The following is a description of a gene set: from publication Chen Y, Wang X (PMID 31504780) Genes predicted to be targets of miRBase v22 microRNA mmu_miR_467g in miRDB v6.0 with MirTarget v4 prediction scores > 80 (high confidence targets). Mouse Gene Set: MIR_467G species: Mus musculus, and this is the list of marker genes: Zc3h12c, Trim59, Abi1, Srsf2, Sclt1, Zmat1, Fbxl17, Cacna1g, Zfp874b (NCBI Gene Id 408067), Aurka, Taok1, Smad1, Adamts20, Ppat, Ikbkg, Ptprb, Rc3h2, Zfp592, Rab39 (RAB39, member RAS oncogene family), Tceanc, Qrich1, Fsd1l, Erich1, Tjp2, Ttc7, Ms4a4c, Frmd6, Marchf6, Mat2b, Kbtbd3, Btf3l4, Zfp354c, Ptp4a3, Klhdc2, Tm9sf3, Cdk6, Epc2, Ccdc166, Extl2, Pias1, Tnfrsf11b, Arhgef10l, Fam8a1, Rb1cc1, Tent5a (NCBI Gene Id 320335), Ric1, Trhr (thyrotropin releasing hormone receptor), Hook3, Rnf111, Rcn2, Adra1b, Cep126, Pou2f1, Irf1, Secisbp2l, Ash1l, Cxcl5, Ankrd13c, Plxna2, Lin52, B3galt1, Prkcd, Mpzl1, Itch, Ednra, Morc3, Tbc1d24, Shoc2, Cttnbp2, Vmn1r51, Spock3, Lin54, Lss, Slc4a7, Fhip1b, Anln, Mis18a (NCBI Gene Id 77054), Fgfr2, Tlr3 (toll-like receptor 3), Phactr2, Tada1, Abcg3, Kif23, Txndc9, Hoxb3, Dusp10, Lrp12, Lrrn1 (NCBI Gene Id 72710), Trhde, Epha4, Grk6, Smad7, Clcn2, Ets1, Dach2, Arhgap6, Gata3, Herc6, Rusc2, Nup93, Zfand2a, Gnaq, Lhx8, Nfyb, Eml6, Sft2d3, Zbtb49, Pik3c2a, Gramd1c, Lats1, Akr1c20, Slc5a3, Mdp1, Akap13, Slc16a10, Pms1, Cxcl16, Rsbn1, Ptpn4, Ell2, Txlnb, Riok3, Lifr, Tshz3, Zmym2, Tfg, Far1, B3galt2, AI182371, Usf3, Fut9, Psd3, Ube2a, Klf15, Slc38a2, Pgm2l1, Sbf2, Bmp5, Nr2c2 (NCBI Gene Id 22026), Cadm2, Tnfaip8, Cmtr2, Kcne4, Arl6ip6, Smu1, Mllt3, Etaa1, Rbm39, Nek1, Lcorl, Akain1, Pdcd10, Hopx, Gucy1a2, Tmtc4, Ccdc68, Grem2, Zmym5, Scamp2, Chuk, Trdmt1, Cdc14a, Fgf4, Traf3ip1, Pip4k2c, Sema4b, Cobll1, Mast4, Scn2a, Gabpa, Cflar, Oas3, Cxxc4, Kdm6a, Osbpl8, Arap2, Plag1, Adgre4, Nhlh1, Rab11fip3, Rif1, Epha5, Zfp27, Fchsd2, Rps6ka3, Phactr4, Tob2, Piezo2, Vamp1, Pdik1l, Skint7, Cdh2, Tmem151a, Sp4, N6amt1, Mtmr12, Pfkfb2, Wdr47 (WD repeat domain 47), A830018L16Rik, Pkd2, Mpc1, Hectd2, Mzt1, Zfp148, Vps35, Zbtb10, Znrf3, Alg6, St8sia4, Fzd8, Chrdl1, Cask, Dkk3, Dmxl1 (Dmx-like 1), Crebrf, Zfand5, Arhgap35, Tnrc6c, Psma3, Kcnh8, Nxpe3, Kif16b, Trpc1, Fgf12, Zswim6, Arfgef2, Hhip, Stard13, Rad21 (NCBI Gene Id 19357), Tgfbr3, Diaph2, Zbtb2, Epb41l2, Dlx4, Usp1, Gopc, Syncrip, Dnttip2, Strbp, Cysltr1, Vps26a, Hnrnpll, Ttll7, Cep135, Kcnma1, Phf6, Lemd3, Prr12, Six6, Ddx10, Fgl2, Cul3, Prpf4b, Aff4, Zfp644, Zdhhc21, Tet3, Lypd1, Iqschfp, Necab1, Tigd5, Rab14, Kcns2, Slc30a1, Des, Polr3d, Rai1, Nck2, Nup35, Qtrt2, Rbbp5, Yes1, Rgmb, Casz1, Topbp1, Crybg3, Ubqln2, Tbc1d22b, Rev1, Grip1, Dcdc2a, Sema3a, Ewsr1 (Ewing sarcoma breakpoint region 1), Il1rap, Atosa, Med14, Cyth3, Skint9, Fignl1, Gtpbp2, Dck, Irs1, Dip2b, Hivep1, Rnf44, Fam228b, Tcf12, Rreb1, Slitrk4, Vcan, Fam118b, Sav1, Ap1g1, Csn2, Mstn, Rhobtb1, Hoxd1, Ptprr, Rasef, Sgms1, Cdc42se2 (CDC42 small effector 2), Wrnip1, Yaf2, Irf2bpl, Gabra1, Calca, Megf11, A630023A22Rik, Styx, Zfp781b, Tab2, Zc2hc1a, Tubgcp5, Prkacb, Rmnd5a, Slc1a1, Pter, Slco2b1, Neurod1, Camsap2, Lrig3, Hnrnpa3, Dennd4a, Cxcl1, Otud6b, Pik3r1, Mapk1, 1700028K03Rik, Nodal, Ctdsp1, Arl8a, Orc1, Lrp8, Ppp1r9b, Nectin4, Baz2b, Dync1li2, Evx2, Krt73, Il1b, Slc8a1 (solute carrier family 8 (sodium/calcium exchanger), member 1), Ano4, Sim1, Emc7, Eif4ebp1, Cfap20, Chrna1, Acsl4, Btaf1, Dph6, Schip1, Arl15, Wrap73, Hs3st3b1, Pak2, Wdr43, Glis3, Taf4b, Itgb1, Fbxo33, Pum2, Homer1, Kcna2, Chek2, Gtf2b, Nceh1, Cadm1, Neurod6, Mthfd1, Adamts1, Ccnc, Ccdc169, Scoc, Bche, Tpm1, Appl1, Tbx22, Adgrf5, Zfp608, Heatr5b, Igfbp1, Pira12, Snx27, Ppm1h, Serpinb9d, Cacnb2, Dleu7, Saxo2, Arhgef7, Lamtor3, Grhl3, Fam76b, Spred1, Epb41l1, Naa20, Mbnl1, Itpr1, Pafah1b1, Car8, Dapk1, Zfp521, Mkrn3, Mcu, Dnajb12, Zfp446, Utp18, Glrb, Phrf1, Filip1l, Zfp689, Cd53, Nectin3, Unk, Nfatc1, Sorcs3, Wiz, Wdfy3, Iars2, Cnbp, Ddx60, Ctsc, Rtp1, Mospd2, Itga2, Apobec3, Akap12, Rbm41, Slc7a2, Pbrm1, Akap7, Tmprss5 (NCBI Gene Id 83680), Sumf2, Slc5a8, Il3, Tulp4, Ncam2, Grm5, Dbx1, Rnf144a, Nfkbia, 1110059G10Rik, Lix1l, Grsf1, Anks1b, Fgd4, Matn2, Mbd2, Dcun1d4, Kif13a, Bmpr2, Mei4, Eri1, Vegfa, Pcf11, Apool, Pfkfb3, Myt1l, Cspp1, Mrc1, Ulk2, Atad1, Ints6l, Ctdspl2, Sf3a1, Slc6a6, Nrf1, Gm11992, Mef2a (myocyte enhancer factor 2A), Gm5592, Ndrg4, Reck, Zfp36l1, Serpinb9g, Dst, Hnrnpd, Gabra2, Rufy2, Spry1, Rnf214, Sart3, Loxl3, Jph1, Aspm, Mfhas1, Rad51d, Tmem196, Gpm6b, Ythdc2 (YTH domain containing 2), Prrx2, Zc3h4, Uty, Timm8a1, Rgs4, Rabgap1l, Zfp143, Cdkn2aipnl, Sirt1, Camk2d, Pi15, Ttc38, Klhl14, Cd209a, Tmf1, Bmper, Xkr6, Ankrd1, Il21, Gucy1b1, Atp2b4, Rock2, Csrnp3, Slc7a11, Asah1, Cldn34c1, Pmp22, Gm5114, Zfp266, Luc7l2, Pcsk5, Maco1, Dlg2, Msx2, Rnf38, Gpatch8, Zbtb44, Col23a1 (collagen, type XXIII, alpha 1), Krit1, Golph3, Golt1a, Tafa1, Tle4, Pea15a, Gje1, Ino80d, Rictor, Matcap1, Wt1, Cwc22, Tagln2 (NCBI Gene Id 78395), Gfod1, Nom1 (nucleolar protein with MIF4G domain 1), Spty2d1, Rbm24, Nup155, Mtmr6, Carmil1, Lrch2, Slc12a6, Ralgapa1, Mfsd2a, Fosb, Slc18a2, Golim4, Mex3b, Hace1, Ssbp2, Smad9, Fbh1, Omg, Zfp407, Mrpl39, Dcun1d3, Setd2, Rerg, Wnt3, Gm4884, Nr3c2, Necap1, Svil, Or52n4, Rnf138, Ube3a, Cnih4, Glipr1l2 (GLI pathogenesis-related 1 like 2), Avl9, Mkrn2os, Bpnt2, Mid2, Runx2, Cstf3, Car5b, Cenpi, Gm6377, Cks2 (NCBI Gene Id 66197), Satb2, Zfp397, Xiap, Carf, Mkln1, Dennd2b, Cbln1, Mex3c, Spag9, Cenpc1, Lrrc42, Tmc8, Pax9, Reps2, Usp6nl, Foxf2, Mdm1, Stxbp5, Ier3, Fech